The following is a description of a gene set: A small membrane-bounded vesicle that releases its contents by exocytosis in response to insulin stimulation; the contents are enriched in GLUT4, IRAP and VAMP2. Mouse Gene Set: GOCC_INSULIN_RESPONSIVE_COMPARTMENT studied in species Mus musculus, and this is the list of marker genes: Rab10, Pikfyve, Rab4b, Myo5a, Slc2a4, Rab4a, Dennd4c, Akt2, Lnpep, Lrp1, Rab13